The following is a description of a gene set: A membrane coat adaptor complex that links clathrin to a membrane. Mouse Gene Set: GOCC_CLATHRIN_ADAPTOR_COMPLEX studied in species Mus musculus, and this is the list of marker genes: Ap2a2, Ap1b1, Ston1, Btbd8, Ston2, Ap1s2, Ap2m1, Ap4m1, Tbc1d5, Slc18a3, Aftph, Ap2s1, Ap1m2, Ap1s1, Clba1, Ap1m1, Ap3m2, Ap1g1, Ap2b1 (NCBI Gene Id 71770), Snap91, Lrrn3, Ap3m1, Ap3b1, Ap1s3, Ap2a1, Eps15, Ap1g2, Sgip1, Ap4b1